Given this list of marker genes SEMA3C, RASSF7, DDT (NCBI Gene Id 91323), OTUD1, MYO15B, HOXB-AS3, EFNA4, PHKG2, LAMA4, CADM1, TUBGCP6, STAT6, NOG, SIVA1, TMEM80, IP6K2, CITED2, PKN3, PLEKHH3, TRPT1, LIG1, SEMA4C, LINC02381, DOCK4, TSHZ2, LINC02315, LPCAT4, ENGASE, NR4A2, TRAF1, PGP, HAGHL, COMTD1, DDB2 (NCBI Gene Id 1643), PAQR4 (progestin and adipoQ receptor family member 4), JUND, WDR90, ENC1, SPSB3, MAMDC4, RAB26, STAT2, KLF6, SKIC2, PCDH7, PBXIP1, TAFAZZIN, TRIB2, NBEAL2, TMUB2, HOXC6, TYK2, ARHGAP5-AS1, ACTR1B, SLC35E2A, IQGAP3, CES3, NOXA1, PPP1R16A, ENTR1, PPP1R35, H4C14, ACAP3, LYPD1, H1-0, PSME1, CTDSP1, OGDHL, PDE5A, CXXC4, RIN2, TONSL, CDK10, ZNF608, CDC20 (NCBI Gene Id 991), PIK3R3, NFATC4 (NCBI Gene Id 4776), KLHL17, NRP1, TNIK, KIF20A, FLRT3, TCP11L2, HOXB9, PIGQ, PLD1, HDAC6, FJX1, SFMBT2, HOXB7, CDKN2C, KLRK1-AS1, DHRS3, SNORA73A, TRHDE-AS1, AKR7A3 (NCBI Gene Id 22977), ITGA10, ENSG00000291006, TOP3B, SEMA3B, VIM, KLF9, NAGLU, TK1, EPRS1, MATCAP1 (NCBI Gene Id 654077), DPP7, NT5C, METTL26, SCARNA12, SHOC1, TCF25, RPL22L1, HOXB6, CROCC, CYBC1, ABCA7, H1-10, NME3, PHLDB2, PLAT, MFSD3, MECOM (NCBI Gene Id 4197), SNHG8, RFNG, LRRC45, PDGFC, FBXO44 (NCBI Gene Id 93611), VIM-AS1, SNORD35B, DEPP1, PLCXD1, SGSM3, DDTL, ZFTRAF1, NEURL1B, KIFC2, SNHG32, ROBO1 (roundabout guidance receptor 1), RHPN1, SLC2A8, SAPCD2, SGSM2, LAMB2, HMG20B, FANCE, RECQL4, TBC1D9, OBSL1, ID3, SEMA6C, CHTF18, CHKB-CPT1B, SPG7, DACT1, MAP3K12, PTGS2, DDIT4, H2AC6, SMOC1, AMDHD2, PIDD1, TXNIP, GPR39, RHOT2 (NCBI Gene Id 89941), MANBA, H4C15 (NCBI Gene Id 724021), MOV10, here is a description of the gene set: The NRF transcription factors NRF1, NRF2, and NRF3, are a subset of Cap'n'collar transcriptional regulators which modulate the expression of genes harboring antioxidant-response element (ARE) sequences within their genomic loci. Despite the emerging physiological importance of NRF family members, the repertoire of their genetic targets remains incompletely defined. Here we use RNA-sequencing-based transcriptional profiling and quantitative proteomics to delineate the overlapping and differential genetic programs effected by the three NRF transcription factors. Comparing our data to recent profiling analyses, we create consensus target gene sets regulated by NRF1, NRF2, and NRF3, genetic programs which we determine to be differentially regulated in human tissues. Together, our data provide a quantitative assessment of how NRF family members sculpt proteomes and transcriptomes, essential information for future studies evaluating the role of NRF factors in normal physiology and disease. from publication Ibrahim L, Mesgarzadeh J, Xu I, Powers ET, Wiseman RL, Bollong MJ (PMID 33096892) species: Homo sapiens Human Gene Set: IBRAHIM_NRF2_DOWN Genes down-regulated in HEK293T cells overexpressing FLAG-NRF2